The following is a description of a gene set: species: Homo sapiens A type of weakness of the bulbar muscles (muscles of the mouth and throat responsible for speech and swallowing) that occurs after a muscle group is used and lessens if the muscle group has some rest. That is, there is diminution of strength with repetitive muscle actions. Human Gene Set: HP_FATIGABLE_WEAKNESS_OF_BULBAR_MUSCLES Fatigable weakness of bulbar muscles, and this is the list of marker genes: OBSCN, PRPH, GLT8D1, MYL2, LRP12, NGLY1, NOTCH2NLC, LPIN1, ANG, GIPC1, CFAP410, MAP3K20, COA8, NEK1, HACD1, DKK1, TBK1 (NCBI Gene Id 29110), UNC13A, TARDBP, SELENON, PPARGC1A, HNRNPA1, TPM3 (tropomyosin 3), CCNF, ANXA11, KLHL41, PON3, UBQLN2, ITGA7, ERBB4, DCTN1, MT-CO1, ADSS1 (adenylosuccinate synthase 1), ACTA1, RILPL1, MYPN, MTM1, VAPB, CHMP2B, DAO, NEFH, GLE1, PON2, FIG4, TAF15, CHCHD10, FUS, TREM2, KBTBD13, SOD1, PON1, DES, NEB, GMPPB, ATXN2, TPM2, MT-CO3, OPTN, PFN1, MATR3, VCP, SQSTM1